Given this list of marker genes PTPRC, CD248, FABP1, EREG, RGR, OLFM1, CD48, STARD7, DNASE1L1 (deoxyribonuclease 1 like 1), ARHGEF16, IPO7, SSR3, DAZAP1, TLR5, LINS1, CIITA, SNX3, PTBP3, CFDP1, B4GALT7, CIC, IL10RA, COCH, SORL1, GMPR2, CDCA8, GABRG2, BSN, BCL2L13, SSTR2, GPATCH4, ACTR1A, TAF12, ARL4A, TRDV2, GEMIN4, ANKRD40, INPP5J, STOM, SLC25A5, JADE2, SCAND2P, RARS2, ELOA-AS1, HMX1, NLGN1, SIRPB1, CASP8, FBXO2, RPL35A, AHCY, CYP2F1, BTG2-DT, CBX1, MYCL, ZIC1, SRSF5, CMAS, FAM136A, PTEN (phosphatase and tensin homolog), USP21, HNRNPUL2, RSL1D1, LFNG, CS, SMC4, CD1C, AICDA, THBS2, KLHL11, NEFM (neurofilament medium chain), DCAF6, PCBP2, IL12B, DICER1, ALG13, ZFYVE21, PRC1, CHM, SMG7-AS1, TMPO, ITPK1, EPB41, KATNA1, NARS2, ELF3, HSPA8, RXRA, ADGRE2, CXCL1, DYNC2LI1, TCEAL1, MBP, MKRN7P, MMADHC, ERO1A, RAB27B, MYOM2, PRPSAP1, SYCE1L, MTARC1, GGA3, KMT5A, SRPRB, CDK5R1, SOX3, HPCA, SLC25A32, ASS1, PTH, CAMKK2, ZNF93, PLK2, BRCC3, PITRM1, ABCG1, EIF3B, TAF1, NFATC3, RPL4, GNLY, LRRC47, TM9SF2, EXOC5, SLC41A3, HIPK3, DNAJA2, GPM6A, MFSD1, FGFR2 (NCBI Gene Id 2263), PDE3B, PUS7, DNAAF2, EIF2S3, TBC1D31, NSUN6, KCTD12, RBMX, GAS2, IL18, HAND2, MFAP1, MARCHF8, SATB2, TOGARAM1, PTGIS, CSN2, TECPR2, SPATA7 (spermatogenesis associated 7), KHSRP, CTSE, TUG1, NAALAD2, ZNF33B, MSN, CARS2, OSGIN2, MRPL39, NR4A2, RPL15, GAS1, GABRA2, SDHA, ITGA4, SKAP2, LPAR1, ZMPSTE24, METTL1, DUSP1, SEMA6D, PPFIBP1, PSME2, PTGDR, LYST, CANX, SSH1, RASSF1, ZNF3, GID8, TOMM40, NLRP2, EXD2, ALDH3A2, RPL36A, RMND1, APEX1, FOSB, MTAP, IL27RA, KCTD20, NEFH (neurofilament heavy chain), GLUD1, GNL3L, EEF1A1, ZFP36L2, CAPN6, IGBP1, CHRM3, here is a description of the gene set: studied in species Homo sapiens Genes up-regulated in comparison of monocytes from LAIV influenza vaccinee at day 7 post-vaccination vesus those from TIV influenza vaccinee at day 7. from publication Nakaya HI, Wrammert J, Lee EK, Racioppi L, Marie-Kunze S, Haining WN, Means AR, Kasturi SP, Khan N, Li GM, McCausland M, Kanchan V, Kokko KE, Li S, Elbein R, Mehta AK, Aderem A, Subbarao K, Ahmed R, Pulendran B (PMID 21743478) Systems vaccinology has emerged as an interdisciplinary field that combines systems wide measurements and network and predictive modeling applied to vaccinology. Here we used the systems vaccinology approach to study the molecular mechanisms underlying th Human Gene Set: GSE29618_LAIV_VS_TIV_FLU_VACCINE_DAY7_MONOCYTE_UP